The following is a description of a gene set: Mouse Gene Set: GOBP_REGULATION_OF_NERVOUS_SYSTEM_PROCESS Any process that modulates the frequency, rate or extent of a neurophysiological process, an organ system process carried out by any of the organs or tissues of the nervous system. species: Mus musculus, and this is the list of marker genes: Chrna7, Nmur2, Mtnr1b, Ccl3, Srebf2, Mtmr2, Abcb1a, Slc25a12, Sox10, Atpsckmt, Grip2, Shank1, Chrna5, Gria1, S100b, Mgll, Il6, Celf4, Ffar3, Avp, Nrxn2, Zfhx2, Gpr35 (NCBI Gene Id 64095), Gba1, Cntnap2, Fgfbp3, Nmu, Lpin1, Ncmap, Dlg4, Eif4a3, Tnf, Unc13b, Grin2a, Abat, Slc8a3, Ghsr, Tppp, Ifng, Npy2r, Grm1, Pawr, Ghrl, Chrnb2, Baiap2, Chrna2, Rims2, Gsk3b, Acp3, Tmem25, Eif4a3l1, Plk2, Nrxn1, Mir23a, Igf1, Wasf3, Prkar1b, Itga2, Zfp488, Smr3a, Shisa7, Ssh1 (slingshot protein phosphatase 1), Htr2c, Prkcz, Avpr1a, Ntsr1, Ctsc, Rnf10, Smr2l, Trpa1 (NCBI Gene Id 277328), Pclo, Tbc1d24, Agt, Dicer1, Tmem100, Rgs4, Hcrt, Fig4, Dag1, Shisa6, Afdn, Rock2, Cux2, Chrnb4, Myrf, Nlgn3, Grin2c, Shank3, Kcnc4, Ngfr, Grk2, Itgax, Grin2b, Hgf, Jam2, Igsf11, Dmpk, Wnt7a, Pten, Adora1, Rapgef4, Spx, Sgms1os1, Eif4a3l2, Ptk2b, Homer3, Grik2, App, Qki, F2r, Nlgn4l, Cst7, Mag, Fgf12, Grin2d, Rims1, Nos3, Tac4, Notch1, Shisa9, Prkn, Gpr171, Lrp8, Eif2ak3 (eukaryotic translation initiation factor 2 alpha kinase 3), Glra1, Hnrnpk, Trf, Pard3, Grin1, Dvl1 (dishevelled segment polarity protein 1), Cacng4, Drd4, Tymp, Begain, Stx1b, Cacnb3, Fmr1, Ccn3, Lrrk2, Tac1, Cacng7, Sh3gl1, Homer1, Grm3, Tnfrsf21, Pirt, Tenm4, Fabp5, Smr2, Tnfrsf1b, Nlgn1, Nlgn2, Cbln1, Adrb2, Reln, Tmem108, Nrdc, Tafa4, Zmynd8, Cartpt, Tnr, S1pr2, Grik1, Tmem98, Stx1a, Egr2, Dlgap2, Cdk18, Neto1, Neto2, Igsf9b, Dbn1, Slc8a2